The following is a description of a gene set: Any process that results in a change in state or activity of a cell or an organism (in terms of movement, secretion, enzyme production, gene expression, etc.) as a result of a cobalt ion (Co2+) stimulus. studied in species Homo sapiens Human Gene Set: GOBP_RESPONSE_TO_COBALT_ION, and this is the list of marker genes: CASP9, SERPINF1, ALAS1, TIGAR, BNIP3, D2HGDH, CASP8, CASP3, ATF1, ALAD